The following is a description of a gene set: species: Mus musculus Mouse Gene Set: MIR_7005_5P from publication Chen Y, Wang X (PMID 31504780) Genes predicted to be targets of miRBase v22 microRNA mmu_miR_7005_5p in miRDB v6.0 with MirTarget v4 prediction scores > 80 (high confidence targets)., and this is the list of marker genes: Dusp9, Sidt2, Niban2, Itga5, Fgf18, Spart, Mical2, Rnf20, Mecp2, Scimp, Rab6b (RAB6B, member RAS oncogene family), Gpr37l1, Atxn1l, Iqsec3, Sfxn1, Sdc3, Plxnc1, Lypd6, Rnf44, Tnrc6b, Kcnk3, Meis2, Dpp10, Heyl, Crhr2 (NCBI Gene Id 12922), Hmox1, Fbrs, Mat2a, Gab2, Atp8b2, Lrsam1, Aqp9, Mcpt1, Pxn, Psmd8, D6Ertd527e, Tbc1d15, Cd320, Kcnj10, Skint3, Mad1l1, Krtap5-2, Cdr2l, Eipr1, Ubiad1, Selenon, Nr1i3, Slc25a42, Ccdc178, Fbxl20, B3galt1, Hspa12a, Ppp1r10, Cdk5r2, Sox6, Csmd2, Prom2, Mllt11, Dcun1d3, Capn12, Phactr1, Sh3pxd2a, Tspan2, Lbh, Fggy, Agtr1b, Fancd2, Nsd1, Mal2, Nr6a1, Vat1, Vav3, Mtrf1l, Mpdu1, Igsf9b, Pin1, Dhx33, Ptprf, Pggt1b, Cic (capicua transcriptional repressor), Kdelr1, Scd1, Eda (NCBI Gene Id 13607), Pou3f3, Tmem209, Tent4b, Adam19, Pskh1, Tet3, Ctso, Arfip1, Zfx, Stk25, Numa1, Rbmx, Plagl1, Magi1, Srcap, Plxna1, Ermp1, Cyp2s1, Fxyd2, Zbtb4, Kcnma1, Pls1, Adcy9, Tanc2, Fbxl17, Elmod1, Zranb2, Lzts3, Xpo7, Naa40, Prkar1b, Tex261, Alkbh6, Ccna2, Wdr48, Dagla, Susd2, Slc25a40, Ehd2, Dennd11, Eeig1